Given this list of marker genes FGF23, FGF5, FGF9, GAB1, FRS2, FGF20, FGF17, FGF18, GRB2, FGF8, FGF1, FGF2, PIK3CA, FGFR3, PTPN11, FGF4, PIK3R1, FGF16, here is a description of the gene set: Reactome Pathway: PI-3K cascade:FGFR3 species: Homo sapiens part of: Downstream signaling of activated FGFR3 The ability of growth factors to protect from apoptosis is primarily due to the activation of the AKT survival pathway. P-I-3-kinase dependent activation of PDK leads to the activation of AKT which in turn affects the activity or expression of pro-apoptotic factors, which contribute to protection from apoptosis. AKT activation also blocks the activity of GSK-3b which could lead to additional antiapoptotic signals.